The following is a description of a gene set: Human Gene Set: BENPORATH_ES_1 Cancer cells possess traits reminiscent of those ascribed to normal stem cells. It is unclear, however, whether these phenotypic similarities reflect the activity of common molecular pathways. Here, we analyze the enrichment patterns of gene sets associated with embryonic stem (ES) cell identity in the expression profiles of various human tumor types. We find that histologically poorly differentiated tumors show preferential overexpression of genes normally enriched in ES cells, combined with preferential repression of Polycomb-regulated genes. Moreover, activation targets of Nanog, Oct4, Sox2 and c-Myc are more frequently overexpressed in poorly differentiated tumors than in well-differentiated tumors. In breast cancers, this ES-like signature is associated with high-grade estrogen receptor (ER)-negative tumors, often of the basal-like subtype, and with poor clinical outcome. The ES signature is also present in poorly differentiated glioblastomas and bladder carcinomas. We identify a subset of ES cell-associated transcription regulators that are highly expressed in poorly differentiated tumors. Our results reveal a previously unknown link between genes associated with ES cell identity and the histopathological traits of tumors and support the possibility that these genes contribute to stem cell-like phenotypes shown by many tumors. species: Homo sapiens from publication Ben-Porath I, Thomson MW, Carey VJ, Ge R, Bell GW, Regev A, Weinberg RA (PMID 18443585) Set 'ES exp1': genes overexpressed in human embryonic stem cells according to 5 or more out of 20 profiling studies., and this is the list of marker genes: IDO1, CBS, GNPTAB, ETV1, RCC1L, CDT1, AKIRIN1, DDX18, CRABP1, USP9X, MAL2, AP1M2, PRPF40A, ATP1A2, SSB, PAK1, KLHL7, MTA3, CCNB1, IGF2BP3, CCNA2, CKMT1A, NOLC1, CEBPZ (CCAAT enhancer binding protein zeta), PARP1, DLG3, SRSF1, SYNGR3, NUP107, CYP2S1, ZNF589, CHEK1, SFRP1, MAP7, PPP2R1B, TTLL12, ACTC1, MCM5, MAN2A1, NCAPG2, PMAIP1, L1TD1, LYPLA1, G3BP1, MFGE8, GPC4, CASP3, PIPOX, BOP1, PCDH1, UTF1, CNMD, SLC29A1, ALPL, EPB41L4B, GART, BUB3, EGLN3, SEMA6A, ABCE1, HMGA1, PAK1IP1, PODXL, TRIM24, FGFR1, TDRP, PRIM1, PUS7, TFAM, AURKB, CAMKV, MGME1, PTPRZ1, TENT5B, PLCB3, ILF3, ZIC3, KIF4A, BRIX1, CDC25A, PRKX, ADGRG2, PLAAT3, MCM10, POLE2, SRSF7, PDK1, ETV4, KCNS3, GINS4, ZNF195, MARS1, BCL2L12, PIM2, SCGB3A2, GABRB3, LRIG1, CYP26A1, TMPO, NOC3L, PRDM14, RRM2, FOXD3, CRMP1, ITPR3 (inositol 1,4,5-trisphosphate receptor type 3), PRPS1, JARID2, PSIP1, TEAD4, ROBO1, HOMER1, SPC25, COCH, NMRK2, DBNDD1, HMMR, SALL4, NANOG, RAB3B, LGALS8, SLC38A1, CAPRIN2, DNA2, TCF7L1, FANCL, MICB, OAZ2, POU5F1, NUDT1, VSNL1, MCM2, NAA15, HESX1, LRP8, HSPD1, ADA2, AZIN1, FZD7, SALL2, GABRA5, MIS18A (MIS18 kinetochore protein A), GPM6B, NOP56, DDIAS, CHST7, ANGEL2, MIS18BP1, FXR1, PRMT3, CBX5, AMD1, CCAR1, ICE2, TMX1, NLGN4X, SLC16A1, CTSC, CACHD1, TRIM22, MTHFD1, DLGAP5, TMEFF1, PIMREG, KLKB1, POLR3G, SERBP1, SORL1, MED14, PDCD2, GAD1, LIN28A, ZIC2, TIA1, TUBB4B, PNN, NLN, GJA1, GPR19, CLDN6, FGF2, CRABP2, MTF2, SEPHS1, NOL11, LARP7, PIK3CB, ZNF770, ADD2, ZSCAN10, DIDO1, RRP15, SIRT1, AUTS2, FZD5, EPCAM, RABGAP1L, NODAL (nodal growth differentiation factor), GAL, SFRP2, FRAT2, TNNT1, USP44 (ubiquitin specific peptidase 44), SRA1, GLDC, ESRP1, SMS, LCK, PAICS, PROM1, HELLS, MAK16, ST6GAL1, PLPP1, PARPBP, ERCC6L, MDN1, ACTA1, DMKN, RUVBL1, MSH6, SLC6A8, HMGB3, NDUFAF4, MSH2, HPS3, DIAPH2, EXOSC5, PITPNC1, MAD2L2, KIF2C, AEN, G3BP2, CER1, LGR4, RPS24, ELOVL6, NFYB, MCM7, RARRES2, NOP16, NUDT21, BUB1B, WDR12, IGF2BP2, RRAS2, SCNN1A, KIF5C, THEMIS2, MCM4, CDC6, GPR176, INTS13, NUDT15, BUB1, PTTG1, KAT7, ZNF398, RNF138, RFC4, ABHD17B, LEFTY1, GPRC5B, CSE1L, BIRC5, OIP5, CRIPTO, MRS2, KRT8, LSR (NCBI Gene Id 54595), RAP1GAP2, DSCC1, MCM6, SLC13A3, WDHD1, DEK, MGST1, NMU, PFAS, FGF13, SLC7A3, NTHL1, PUS1, DDX21, NTS, DSG2, FABP5, ARL5B, BRWD1, C1QBP, NASP, AASS, LARGE2, SNRPN, TMEM177, CNTNAP2, PPM1B, HNRNPAB, PTPN2 (NCBI Gene Id 5771), DCLK1, USO1, RCC2, PRKD3, RAD54B (RAD54 homolog B), SINHCAF, OLFM1 (NCBI Gene Id 22825), KPNA2, HSPA8, PPP2R2B, EPRS1, CHAF1A, CDCA5, ZNF267, NFE2L3, JADE1, ADAM23, NUP37, KIFC2, M6PR, HAS3, SOX2, SPRY4, PNISR, RBBP8 (NCBI Gene Id 5932), RFC3, COBL, DNMT3A, FKBP5, CHEK2, TERF1, NDC1, DHFR, ZGRF1, DNAJB6, DPPA4, ORC1, ESF1, CXADR, SLC39A10, ACTN3, CDK1 (NCBI Gene Id 983), MCM3, PYCR2, MIR124-1HG, PRIM2, EXOSC9, VRTN, TUBB2B, BMPR1A, SNRPA, GMNN (NCBI Gene Id 51053), DNMT3B, NCAPH, RAD51AP1, TNPO3, FUBP1, UNG, UGP2, GNL3, NPM1, EPHA1, CD24, MRE11 (NCBI Gene Id 4361), FEN1, LRRN1, IFITM1, GDF3, MAT2A, HSPA4, MTHFD2, GINS2, CDC20, FOXO1, NPM3, ECT2, SALL1, ANOS1, ERBB2 (erb-b2 receptor tyrosine kinase 2), MYO19, PASK